The following is a description of a gene set: The dissemination of mature viral particles from a host cell, e.g. by cell lysis or the budding of virus particles from the cell membrane. studied in species Mus musculus Mouse Gene Set: GOBP_VIRAL_RELEASE_FROM_HOST_CELL, and this is the list of marker genes: Chmp1b, Trim62, Vps4b, Ist1, Vapa (NCBI Gene Id 30960), Trim31 (NCBI Gene Id 224762), Chmp5, Trim25, Vps37b, Vapb, Vps4a, Ddb1, Chmp4b, Cav2, Chmp6, Chmp7, Chmp3, Tsg101, Chmp2a, Chmp4c, Pcx, Chmp2b, Chmp1a, Arl8b, Chmp1b2, Rab7